The following is a description of a gene set: Ethanol oxidation studied in species Mus musculus Mouse Gene Set: REACTOME_ETHANOL_OXIDATION, and this is the list of marker genes: Acss1, Acss2, Aldh1a1, Adh7, Adh1, Aldh2, Aldh1b1, Adh5, Adh4